The following is a description of a gene set: Catalysis of the reaction: a 2'-deoxyribonucleoside 5'-phosphate + ATP = a 2'-deoxyribonucleoside 5'-diphosphate + ADP. Human Gene Set: GOMF_DEOXYNUCLEOSIDE_PHOSPHATE_KINASE_ACTIVITY_ATP_AS_PHOSPHATE_DONOR studied in species Homo sapiens, and this is the list of marker genes: CMPK1, DTYMK, AK4, CMPK2, AK9, AK1